Given this list of marker genes Hes5 (hes family bHLH transcription factor 5), Mycn, Fgf2, Hey1, Hes1, Atoh1, Esrp1 (epithelial splicing regulatory protein 1), Mycl, Notch1, Fgfr3, Dll1, Hey2, here is a description of the gene set: Mouse Gene Set: GOBP_REGULATION_OF_INNER_EAR_AUDITORY_RECEPTOR_CELL_DIFFERENTIATION Any process that modulates the frequency, rate or extent of auditory hair cell differentiation. species: Mus musculus